The following is a description of a gene set: Human Gene Set: GSE34156_UNTREATED_VS_6H_NOD2_LIGAND_TREATED_MONOCYTE_DN human blood monocytes were isolated, activated and harvested at several timepoints In this study, we identified genes that were differentially expressed in human monocytes activated with eiter NOD2L and/or TLR2/1L. studied in species Homo sapiens Genes down-regulated in monocytes (6h): untreated versus muramyl dipeptide. from publication Schenk M, Krutzik SR, Sieling PA, Lee DJ, Teles RM, Ochoa MT, Komisopoulou E, Sarno EN, Rea TH, Graeber TG, Kim S, Cheng G, Modlin RL (PMID 22447076), and this is the list of marker genes: STAT3, TMEM219, ISOC1, PARP8, GTPBP2, CASP1 (NCBI Gene Id 834), CXCL12, CD69, XAF1, TMEM87A, SP100, MYD88, ALDH1B1, PLOD2, CMPK2, IRGM, SLC15A3, AHCYL2, CASP8, ISG20, FBRSL1, ST6GAL1, FATE1, GBP4 (NCBI Gene Id 115361), TRAFD1, OAS2, GTF2F1, SEMA7A, RAPGEF2, TPST1, C3AR1, PARP12, FLRT2, HDC, CASP2, ANKLE2, C19orf38, AXL, NSMAF, ZP2, ABI3BP, LRATD2, DAXX, STXBP1 (syntaxin binding protein 1), LEPROT, COX7B2, MAFK, FRMD4B, CSPG5, LIPG, NDST2, RNF214, LGALS9, TENT5A, TIMELESS, SLC9A9, SERINC1, SDC3, CRYBG1, MBD1, TRIM5, CNP, TOR1AIP2, TAPBP, NUDT13, TRIM21, STOML1 (NCBI Gene Id 9399), HACD4, MTMR11, HELZ2, NMI (NCBI Gene Id 9111), CACNA1E, EHD4, LIPE, ADAP2, IL22RA2, DYNC1I2, STAT1, DENND1C, NSD3, TMEM106A, ATP11B, RBM43, TNFSF8, FCGR1A, CBFB, PHLPP1, RNF34, PHF11, ZEB1, MS4A4A, CPSF2, CCNL1, ASB13, RTN1, SPSB1, DISP3, MTHFR, ATP10A, MYB, TLR3, AP3M2, TRIM34, LMO2, KCTD10, CYP2S1, CCNG2, KMO, HDAC3, RAB1A, ANKS1A, FYN, CORO2A, ZNFX1, GBP5, CDK14, TM9SF4, PLEKHF2, HP1BP3, TMBIM4, PRNP, GBP3, GBP2, PTPRO, NR3C1, RNF135, KLHL28, CDS1, TNFSF10, LUC7L3, KHNYN (NCBI Gene Id 23351), TNFRSF11A, NECTIN4, SENP1 (NCBI Gene Id 29843), IFIT3, SAMD9L, PTTG1, GPSM2, CSRNP1, ZDHHC5, LY6S, RND3, SETDB2 (NCBI Gene Id 83852), GADD45G (growth arrest and DNA damage inducible gamma), USP18, DENND6B, TMEM50B, IFI16, IKZF5, MEF2C, LSM14A (LSM14A mRNA processing body assembly factor), RMDN3 (regulator of microtubule dynamics 3), IFI35, DUSP2, ENDOD1, EDN1, MOV10, NR4A3, PML, FLT1, SLC37A3, DBNL, LRP4, MLLT3, MBD2, CXCL11, CFB, LPXN, ELMOD2, IRF2, SP110, FAM53C, PCGF5, CENPJ, TLE1, TENM1, TBK1